The following is a description of a gene set: The directed movement of a dipeptide across a membrane by means of some agent such as a transporter or pore. A dipeptide is a combination of two amino acids linked together by a peptide (-CO-NH-) bond. Human Gene Set: GOBP_DIPEPTIDE_TRANSMEMBRANE_TRANSPORT species: Homo sapiens, and this is the list of marker genes: SLC15A4, SLC15A3, MFSD1, SLC15A2 (solute carrier family 15 member 2), SLC26A6, CA2, SLC15A1, SLC7A11